The following is a description of a gene set: Human Gene Set: GOBP_RENAL_VESICLE_DEVELOPMENT studied in species Homo sapiens The process whose specific outcome is the progression of the renal vesicle over time, from its formation to the mature structure. An epithelium is a tissue that covers the internal or external surfaces of an anatomical structure. The renal vesicle is the primordial structure of the nephron epithelium, and is formed by the condensation of mesenchymal cells., and this is the list of marker genes: GDNF, KIF26B, PAX8, WNT4, SIX2, SOX9, LIF, SMO, SALL1, PAX2, SOX8, OSR1, STAT1, CTNNB1, WNT9B, GREM1, LHX1